Given this list of marker genes Pank1, Hmgcr, Dcakd, Slc25a42, Mccc2, Acot7, Acat1 (acetyl-Coenzyme A acetyltransferase 1), Nudt8, Coasy, Nudt19, Alpi, Ppcdc, Crot, Pank2, Enpp1, Ppcs, Pank3, Vnn1, Nudt7, Pank4 (pantothenate kinase 4), Slc25a16, here is a description of the gene set: species: Mus musculus The chemical reactions and pathways involving coenzyme A, 3'-phosphoadenosine-(5')diphospho(4')pantatheine, an acyl carrier in many acylation and acyl-transfer reactions in which the intermediate is a thiol ester. Mouse Gene Set: GOBP_COENZYME_A_METABOLIC_PROCESS